The following is a description of a gene set: The series of molecular signals mediated by the detection of a hormone, and which triggers the apoptotic signaling pathway in a cell. The pathway starts with reception of a hormone signal, and ends when the execution phase of apoptosis is triggered. Human Gene Set: GOBP_HORMONE_MEDIATED_APOPTOTIC_SIGNALING_PATHWAY species: Homo sapiens, and this is the list of marker genes: SSTR3, SST, CRH, METTL21C, PTH